The following is a description of a gene set: Mouse Gene Set: GOBP_REGULATION_OF_OPSONIZATION Any process that modulates the frequency, rate or extent of opsonization. studied in species Mus musculus, and this is the list of marker genes: Colec10, Pla2g5 (phospholipase A2, group V), Mbl2, Myo18a, C4bp, Cfp, Fcnb, Zp3r, Colec11